The following is a description of a gene set: Human Gene Set: GSE5142_HTERT_TRANSDUCED_VS_CTRL_CD8_TCELL_LATE_PASSAGE_CLONE_DN studied in species Homo sapiens Genes down-regulated in CD8 T cells: early passage clone over-expressing TERT versus late passage control. from publication Menzel O, Migliaccio M, Goldstein DR, Dahoun S, Delorenzi M, Rufer N (PMID 16951325) Using CD8+ T lymphocyte clones over-expressing telomerase weinvestigated the molecular mechanisms that regulate T cell proliferation. Transduction and subcloning procedures were performed on CD8 + naive T-cell clones isolated from two different healthy individuals aged between 30 to 35 years (HD1 and HD2). T-cell cloneswere transduced to express hTERT/GFP or GFP alone. HD2 was profiled on U133Plus 2.0 and submitted as a separate GEO series., and this is the list of marker genes: MFSD6, CABLES2, PHETA1, PGAP6 (post-GPI attachment to proteins 6), ZHX2, ATP11C, VSIR, BACH1, ABLIM2, PIP4K2B, FRMD6, INPP5A, TCTA, SMAD4, TMEM42, CHM, PHF3 (PHD finger protein 3), MKRN1, RGS2, SLC25A35, GALNT2, MAP3K1, RASSF2, TES, HSBP1, PATL2, TCF7, IRF6, LATS2, MARVELD1, OTUD1, DHRS13, CSGALNACT1, ITPKB, ASCL3, PTTG1IP, THRA, CELF1, KCTD10, FPGT, TP53I13, SPACA1, ADGRE5, SERTAD2, SH3PXD2A, TBC1D30, CPM, ARRB1, SMUG1, PHF23, FOXO4, RFX3, VWCE, KLHL21, SETD3, KIF13B, UGCG, BAG5, POLG, NR3C1, TBC1D20, CDS2, FRAT2 (NCBI Gene Id 93368), CRY2, KHNYN, HLCS (holocarboxylase synthetase), RASSF3, YPEL3, DENND2C, TCN2, INO80, TIRAP, CASC3, CYP21A1P, MINDY1, SMAD7, FRMD8, CCDC82, SHOC2, DNAJB9, ETV3, CYRIA, ABCC5, RNPEPL1, DNAJC6, FLOT2 (NCBI Gene Id 2319), TRIO (trio Rho guanine nucleotide exchange factor), KRAS, LAPTM4A (lysosomal protein transmembrane 4 alpha), MFGE8, RFLNB, PAQR7, RNF44, CHMP1B, TENM1 (teneurin transmembrane protein 1), CDIP1, SBSN, H1-2, RHOB, BAHD1, WBP1L, CDC42SE2 (CDC42 small effector 2), TAGAP, DAPK1, CSNK1E, ZNF274, RRM2B, FAAP100 (NCBI Gene Id 80233), RFX1, KLHL8, BET1L, BRAT1, NBEAL1, SLC36A1, TUBB2A, IER5, FAM120AOS, HID1, RHEBL1, RNF167, H2BC13, TNKS, FCSK, L3MBTL3, KLF6, TMEM204, PIK3C3, KLF7, RNF146, DEGS1, C8orf82, CD1D, ABHD15, RBM48, ETS1, PRKCZ, CYP2D6, RAMP1, ARID1A, PNPLA2, DENND11, PTTG1, TMEM43, ADGRG3, RPS6KA2, TSC22D3, YY1, RASSF8, IL1RL2, PDE4DIP, LEPROTL1, RICTOR, PDE7A, UBE2J1, BCDIN3D, ZMYM5, ZNF394, GALNT9 (NCBI Gene Id 729185), ACAD10, NCKAP5L, USE1, TRIB3, RYBP, DGKD, PDCD6IP, LEF1, PIGP, TTC28, IL6R, RABGGTA, LNPEP, LETM2, MYO9A, TTYH2, PRG4, PITPNM1, KIAA0930, KIDINS220, SAG, NDFIP2, GLG1, MAP4K5, XYLT2, ELAC1, BICRAL, PEX5, GCLC, MICALL1, ZBTB2, RSU1, WIPF2, TVP23B, CAMK1D, MAN1C1, SPPL2A, BTBD19, TEC, STAT5B, STX17, NUMB